The following is a description of a gene set: Human Gene Set: HP_HYPERNATREMIA An abnormally increased sodium concentration in the blood. species: Homo sapiens Hypernatremia, and this is the list of marker genes: ARNT2, SYK, SLC5A1, CA5A, AQP2, AVPR2, GCSH, CRELD1, DSG1, FGFR1